Given this list of marker genes Wnt3a, Plxna3, Sema3a, Sema3f, Slit1, Ryk, Wnt5a, Wnt3, Sema5a, Hdac6, Nrp1, here is a description of the gene set: Mouse Gene Set: GOBP_NEGATIVE_REGULATION_OF_AXON_EXTENSION_INVOLVED_IN_AXON_GUIDANCE species: Mus musculus Any process that stops, prevents, or reduces the frequency, rate or extent of axon extension involved in axon guidance.